The following is a description of a gene set: Human Gene Set: KEGG_MEDICUS_ENV_FACTOR_METALS_TO_RAS_ERK_SIGNALING_PATHWAY Pathway Definition from KEGG: Metals -> ROS -> RAS -> RAF -> MEK -> ERK -> AP1 Metals to RAS-ERK signaling pathway. Pathway ID: N01408. Pathway type: Env factor. Pathway class: nt06210 ERK signaling. studied in species Homo sapiens, and this is the list of marker genes: MAP2K1, BRAF, KRAS, ARAF, FOS, MAP2K2, MAPK1, JUN, NRAS, MAPK3, HRAS, RAF1